Given this list of marker genes ARID5A, PPARG (NCBI Gene Id 5468), NCOR2, VDR, NR0B2, TACC1, ASXL1, NR4A2, MED1, NR1H2, NRIP1, SNW1, CNOT1, HMGA1, ACTN4, NR1H4, NSD1, PRMT2, LRIF1, RARG, NCOA1, NCOA6, RARB, MED25, PRAME, here is a description of the gene set: species: Homo sapiens Binding to a nuclear retinoic acid receptor, a ligand-regulated transcription factor belonging to the nuclear receptor superfamily. Human Gene Set: GOMF_NUCLEAR_RETINOIC_ACID_RECEPTOR_BINDING